The following is a description of a gene set: Human Gene Set: GOBP_NUCLEOTIDE_BINDING_OLIGOMERIZATION_DOMAIN_CONTAINING_2_SIGNALING_PATHWAY studied in species Homo sapiens The series of molecular signals initiated by the binding of a ligand (such as a bacterial peptidoglycan) to a cytoplasmic nucleotide-binding oligomerization domain containing 2 (NOD2) protein receptor, and ending with regulation of a downstream cellular process., and this is the list of marker genes: XIAP, TLR4, IRGM, OTULIN, LACC1, SLC15A4, TNFAIP3, RIPK2, PTPN22, NOD2, NAGK, ERBIN, RELA, INAVA, HSPA1B, HSPA1A, SLC15A3, ZNRF4, IRF5, NFKBIA